Given this list of marker genes AIP, HS6ST1, SEMA3A, SOX10, DCC, IL17RC, HLA-DRB1, IL17RA, MEN1 (NCBI Gene Id 4221), CCDC141, IL17F (interleukin 17F), CCR6, CAV1, FZD2, FGFR1, IRF5, TACR3, WDR11, SPRY4, CHD7, DUSP6, HESX1, CLEC7A, CDH23, FGF8, IKZF1, IL17RD, FLRT3, HLA-B, CCN2, PROKR2, FEZF1, PROK2, NDNF, FGF17, TRAF3IP2, ANOS1, here is a description of the gene set: Recurrent or persistent genital pain associated with sexual intercourse. Dyspareunia Human Gene Set: HP_DYSPAREUNIA species: Homo sapiens